Given this list of marker genes MRAS, KCNK2, L3MBTL3, SH2D4A, TP53RK, SPRY4, WDR26 (WD repeat domain 26), PCDH17 (NCBI Gene Id 27253), LINC02693, UBN2, DLC1, SMPD3, TENT4B, CNOT6, GOLGA3, MMP24, CNOT2, ZMYND11, RNF38, CTDSPL, CEP170, TMEM121B (transmembrane protein 121B), DUSP3, ST6GALNAC6, CXXC4, MECOM, EPB41, PRSS35 (serine protease 35), NCSTN, UBE2G1, TMEM123, TMEM38A, GMIP, CDK16, PDCL, ASXL1, RASSF1, NRF1, MAPRE2, CDC42SE1, SLC35E1, MORC2, TP53INP1, FZD7, CDCP1, NFIX, COPS4, HENMT1, MAN2A2, C3orf18, FJX1, COPZ1, UBTD1, BORA, ELOVL6, PLEKHN1, PTPN7, here is a description of the gene set: from publication Chen Y, Wang X (PMID 31504780) Genes predicted to be targets of miRBase v22 microRNA hsa-miR-504-5p in miRDB v6.0 with MirTarget v4 prediction scores > 80 (high confidence targets). studied in species Homo sapiens Human Gene Set: MIR504_5P